Given this list of marker genes SMPD4, AIMP1, CCN1, SPAG5, ZNF629, CDC6, HSPA1B, CENPF, MYBL2, VEZT, F9, here is a description of the gene set: In this study we used adenovirus vector-mediated transduction of either the p53 gene (rAd-p53) or the p21(WAF1/CIP1) gene (rAd-p21) to mimic both p53-dependent and -independent up-regulation of p21(WAF1/CIP1) within a human ovarian cancer cell line, 2774, and the derivative cell lines, 2774qw1 and 2774qw2. We observed that rAd-p53 can induce apoptosis in both 2774 and 2774qw1 cells but not in 2774qw2 cells. Surprisingly, overexpression of p21(WAF1/CIP1) also triggered apoptosis within these two cell lines. Quantitative reverse transcription-PCR analysis revealed that the differential expression of BAX, BCL2, and caspase genes, specific in rAd-p53-induced apoptotic cells, was not altered in rAd-p21-induced apoptotic cells, suggesting p21(WAF1/CIP1)-induced apoptosis through a pathway distinguishable from p53-induced apoptosis. Expression analysis of 2774qw1 cells infected with rAd-p21 on 60,000 cDNA microarrays identified genes in response to p21(WAF1/CIP1) expression in at least one time point with 2.5-fold change as a cutoff. Integration of the data with the parallel microarray experiments with rAd-p53 infection allowed us to extract genes downstream of both p53 and p21(WAF1/CIP1) and genes in response to p21(WAF1/CIP1) expression in a p53-independent pathway. The genes in the former set may play a dual role in both p53-dependent and p53-independent pathways, and the genes in the latter set gave a mechanistic molecular explanation for p53-independent p21(WAF1/CIP1)-induced apoptosis. Furthermore, promoter sequence analysis suggested that transcription factor E2F family is partially responsible for the differential expression of genes following p21(WAF1/CIP1). This study has profound significance toward understanding the role of p21(WAF1/CIP1) in p53-independent apoptosis. studied in species Homo sapiens Human Gene Set: WU_APOPTOSIS_BY_CDKN1A_NOT_VIA_TP53 from publication Wu Q, Kirschmeier P, Hockenberry T, Yang TY, Brassard DL, Wang L, McClanahan T, Black S, Rizzi G, Musco ML, Mirza A, Liu S (PMID 12138103) Genes downstream of CDKN1A in a TP53 independent pathway in 2774qw1 cells (ovarian cancer).